Given this list of marker genes Trhde, Zfp760, Polb, B3gnt9 (NCBI Gene Id 97440), Uba5, Cdk12, Neil2, Arfgef1, Mgarp, Pclo, Plekha1, Jmjd1c, Gabra1, Vkorc1, Tceanc, Sppl2a, Iqub, Relch, Twf1, Tmem255a, Prr12, Neurod6, Klhl2, Slc4a8, B3galt2, Gabra4, Phf6, Cacnb2, Camk2d, Klhl15 (NCBI Gene Id 76150), Anln, Alcam, Tgfbr3, Arfgef2, En2, Utp18, Ahr, Cxcl16, Hacd2, Pde8b, Tle1, Dsg1c (NCBI Gene Id 211924), Naa30, Susd6, Cpeb3, Asph, Zfp746, Rnf139, Vldlr, Flt3, Asxl2, Hif1a (hypoxia inducible factor 1, alpha subunit), Brwd1, Arhgef17, Wnt3, Zswim6, Pag1, Prok2, Slc30a7, Piga, C5ar1, Glra2, Sbno2, Tspan2, Gulp1, Elac1, Sncb, Pfkfb2, Cxcl2, Gpr155, Cpsf2, Fbxo28, Acly, Pak3, Thsd7a, Hsdl1, Arid4a, Arfgap3, Hoxb7, Bahcc1, Slc4a4, Rbm4, Ctsh, Rftn2, Kdm5b, Nuf2, Atosa, Gpr146, Kcnmb2, Klrc1, Map1b, Csn2, Asb10, Cops7a, Defb1, Grip1 (glutamate receptor interacting protein 1), Adss1, Adam22 (NCBI Gene Id 72849), Tmem135, Rbm8a, Fndc3a, Ccdc82, Tent4a, Ythdf1, Rorb, Sdc2, Xbp1, Ndufaf5, Cnih2, Sbds, Syf2, Bmpr2 (NCBI Gene Id 98751), Hbegf, Rabgef1, Mospd1, Ncapg, Slc5a8, Dach2, Cr2, Parp4, Mc2r, Rfx6 (regulatory factor X, 6), Mllt3, here is a description of the gene set: Genes predicted to be targets of miRBase v22 microRNA mmu_miR_376c_3p in miRDB v6.0 with MirTarget v4 prediction scores > 80 (high confidence targets). from publication Chen Y, Wang X (PMID 31504780) studied in species Mus musculus Mouse Gene Set: MIR_376C_3P